The following is a description of a gene set: Human Gene Set: GOBP_RESPONSE_TO_INTERLEUKIN_15 studied in species Homo sapiens Any process that results in a change in state or activity of a cell or an organism (in terms of movement, secretion, enzyme production, gene expression, etc.) as a result of an interleukin-15 stimulus., and this is the list of marker genes: IL15, STAT5A, IL2RB, IL15RA, PLCB1, STAT3, CD4, JAK1, JAK3, STAT5B, IL2RG